The following is a description of a gene set: Human Gene Set: KEGG_MEDICUS_REFERENCE_RORA_MEDIATED_TRANSCRIPTION studied in species Homo sapiens Pathway Definition from KEGG: (RORA+KAT5) => (ITPR1,SLC1A6,GRM1) RORA-mediated transcription. Pathway ID: N00965. Pathway type: Reference. Pathway class: nt06462 Spinocerebellar ataxia., and this is the list of marker genes: ITPR1, RORA, KAT5, GRM1, SLC1A6